Given this list of marker genes Bcl2l15 (BCLl2-like 15), Slamf1, Fmr1, Prb1a, Ear6, Oog4, Ttll7, Sfi1, Nup160, Gm2042, Pclaf, Kctd18, Nlrp4c, Cdh11, Map7, Ubox5, Pura, Txndc9, Cd8a, Ppp6r2, Npc2, Gabrq, Prb1b, Oog2 (oogenesin 2), Papola, Caps2, Wif1, Synpr, Unc13c, Septin11, Ppp4r3a, Zfp976, Oog1, Folh1, Csmd3, Xlr, Adam19, Ear1, Kmt5a (NCBI Gene Id 98818), Pramel51, Olfm3, Tlr11, Atxn1, Cfh, Pitx2, Manba, Crppa, Dmtf1l, H2-T3, Tlr7, Rabif, Stk39, Mef2c, Pramel26, Mef2a, Ms4a18, Lhfpl6, Tg (thyroglobulin), Braf, Apobec3, Mc2r, here is a description of the gene set: Mouse Gene Set: MIR_675_3P Genes predicted to be targets of miRBase v22 microRNA mmu_miR_675_3p in miRDB v6.0 with MirTarget v4 prediction scores > 80 (high confidence targets). species: Mus musculus from publication Chen Y, Wang X (PMID 31504780)